The following is a description of a gene set: Mouse Gene Set: GOBP_ADENYLATE_CYCLASE_INHIBITING_G_PROTEIN_COUPLED_GLUTAMATE_RECEPTOR_SIGNALING_PATHWAY An adenylate cyclase-inhibiting G protein-coupled receptor signaling pathway initiated by glutamate binding to its receptor, and ending with the regulation of a downstream cellular process. studied in species Mus musculus, and this is the list of marker genes: Grik3, Grm8, Grm6, Grm3, Grm4, Grm2, Grm7